Given this list of marker genes Abat, Htr1b, Htr1a, Gabbr1, Htr6 (NCBI Gene Id 15565), Hrh3, here is a description of the gene set: species: Mus musculus Mouse Gene Set: GOBP_NEGATIVE_REGULATION_OF_GAMMA_AMINOBUTYRIC_ACID_SECRETION Any process that stops, prevents, or reduces the frequency, rate or extent of the regulated release of gamma-aminobutyric acid.